The following is a description of a gene set: species: Homo sapiens Human Gene Set: GOMF_STEROID_BINDING Binding to a steroid, any of a large group of substances that have in common a ring system based on 1,2-cyclopentanoperhydrophenanthrene., and this is the list of marker genes: SYP, HSD11B2, ESRRB, ERLIN1, ESRRG, VDAC2, PAQR7, INSIG1, STARD3, NR3C1, OSBP2, HSD17B1, SOAT1, ESRRA, SCARB2, PROM1, OSBPL1A, OSBPL9, PTCH1, PAQR8, GPR183, GPR155, PAQR9, INSIG2, TMEM97, SMO, KL, GRAMD1C, CYP2R1 (cytochrome P450 family 2 subfamily R member 1), PDIA2, PGRMC1, PGR, NINJ2, OSBPL5 (NCBI Gene Id 57656), GPR141, PAQR5, NR1H4, VDR, S100G, AKR1D1, UGT1A8, STAR, STARD4, PGRMC2, APOF, OSBP, ATP5PO, OSBPL7, AR (NCBI Gene Id 367), UGT1A1, STARD5, RORA, GC, SULT2B1, VDAC1, SLC38A9, ERLIN2 (ER lipid raft associated 2), NR1H3, MINAR2, CD81 (CD81 molecule), SHBG, ATP1A2, APOA1, ATP1A1, ESR1, OSBPL6, SCAP, SOAT2, CALB1, SCP2, ABCG1, APOC3, ANXA6, NFE2L1, GPER1, CYP3A4, ESR2, OSBPL2, CETP, APOD, OSBPL10, TMEM199, SULT1E1, OSBPL3, IRX5, TSPO, GAS1, ATP1A3, NPC2, OSBPL8, SIDT1, CAV1, TSPO2, APOA2, NR3C2, EPHX1, RORC, STARD3NL, GRAMD1B, PROM2, PAQR6, ABCA1, GRAMD1A, PMP2, CYP21A2, HSD11B1, OSBPL11, SERPINA6, NPC1, NPC1L1